Given this list of marker genes HTR3C, HTR3B, HTR3E, HTR3D, HTR3A, here is a description of the gene set: species: Homo sapiens The series of molecular signals initiated by serotonin binding to a seratonin receptor on the surface of the target cell, followed by the movement of ions through a channel in the receptor complex. Ends with regulation of a downstream cellular process, e.g. transcription. Human Gene Set: GOBP_SEROTONIN_GATED_CATION_SELECTIVE_SIGNALING_PATHWAY